Given this list of marker genes TTK, CDK4, EBNA1BP2, NME1, PFKM, ABCB6, CCNA2, BHLHE40, HMGCS1, PLP2, AARS1, TIAM1, GSTP1, CDC6, IMPDH2, LGALS3, MRPL28, AURKB, UMPS, CCNB1, GINS1, PDXK, S100A11, LTA, SERPINE2, VWA5A, NCAPD2 (NCBI Gene Id 9918), YWHAE, IL2, PRDX1, ESPL1, PSMB3, ULK2, RGL1, GNG5, SRGAP2, LPL, COMT, SEPTIN8, FAH, CTPS1, LYST, MKI67, TPX2, TNFSF14, ATF1, COX8A, RLN2, CSF2, DBI, ENO1, DHFR, POLD2, CYFIP1, MIF, CST7, TOMM40, FANCI, LAPTM4B, SAP30, CCL20, DHCR24, ACOT7, MRPS12 (NCBI Gene Id 6183), CXCL12, FABP5, MCM5, FEN1, UBE2C, TWF2, LSM4, GZMH, CCNB2, NEFH, CYB5B, IPO7, GATC, DUSP4, RAD54L, RNF14, PSMG1, COX6A1, GGH (gamma-glutamyl hydrolase), CKS2, GTF2H5, GPX1, GCNT2, VCP, DFFA, MRE11, BDH1, RRM2, MCM2, EN2, PAICS, STAMBP, MMACHC, MYBL2, STX11, TNFRSF9, PDLIM3, CDC25C, SERPINI2, LGALS1, KIF11, CLIC1, MRPL19 (mitochondrial ribosomal protein L19), NFIL3, SHMT2, BRCA1, PHGDH, NUDT1, THOP1, MAP2K3, TACR3, DLGAP5, MELK, TPGS2, ENO2, HSD17B10, TNF, TYMS, GLS2, EEF1E1, SMC2 (structural maintenance of chromosomes 2), CDC45, GZMB, PSMA5 (NCBI Gene Id 5686), KIF3B, ACAT1, H4C3, CALU, NRAS, MCM3, TMEM106C, AURKA, CTNNA1, MRPL23, PCLAF, PCNA, SLC1A5, CD63, RAB27A, CDC20, LDHA, IGFBP2, AHCYL1, EXOSC2, PTTG1, IPO5, MAT2A, PLAGL2, PCK2 (phosphoenolpyruvate carboxykinase 2, mitochondrial), GPI, PMVK, PTMS, ALDOA, DMC1, WDHD1, MICAL2 (NCBI Gene Id 9645), PGK1, PSMA6, CCL5, DOK1, AP4M1, HMGN2, CDKN3, WARS1, FH, SORD, AVPR1A, PLCG2, PPP2R5D (protein phosphatase 2 regulatory subunit B'delta), RUVBL2, ARNT, CENPS, EIF2S1, FANCL, CIT, DGKB, CCT5 (NCBI Gene Id 22948), UBE2S, HSPH1, EZH2, PKM, AHCY, TUBA1B, EXO1, PRDX3, ACTN4, TUBG1, PSMB9, SRM, TRIP10, PNP, RAD51AP1, CENPF, IRF4, MCM4, here is a description of the gene set: Microarray analysis was performed to determine the transcriptional profiles of NKT, CD1d-aGC+ Va24-, and CD4 T cells. species: Homo sapiens Genes down-regulated in CD4 T cells: naïve versus activated. Human Gene Set: GSE28726_NAIVE_VS_ACTIVATED_CD4_TCELL_DN from publication Constantinides MG, Picard D, Savage AK, Bendelac A (PMID 21632718)